Given this list of marker genes Rxylt1, Ddias, Gabrg3, Tm7sf3, Ptpn14, Dglucy (D-glutamate cyclase), Slc19a2, Hpcal1, Zbtb7b, Cpt1c, Ano3, Rap2a, Ggta1, Eda2r, Susd6, Trp53inp1, Sec14l5, Ddit4l, Tbc1d8, Bbc3, Zfp750, Inka2, Cep170b, Gne, Usp2, Tnfrsf10b, Cdkn1a, Ampd2, Nr1d1, Tmem19, Map3k20, Dcxr, Fas, Gm5046, Rhbdf2, H2aj (NCBI Gene Id 632401), Vps36, Trafd1, Pidd1, Hmcn2, Pierce1, Rap2b, Cgref1, Pmaip1, Baiap2, Tap1, Cdc42bpg, Zfp365, Ei24, Pdk4, Ephx1, Btg2, Gtse1, Aen, Phlda3, Kank3, Polk, Rnf169, Zmat3, Apaf1, Foxo3, Plk2, Prrg4, D630023F18Rik, Mab21l3, Ckap2, Slc66a3, Grhl3, Dennd2c, Lpin1, Bloc1s2, Usp32, Gpr75, Ercc5, Sesn2, Mapkapk3, Arap2, Stox2, Igdcc4, Ppm1d, Bax, Dcaf4, Ccng1, here is a description of the gene set: from publication Quintens R, Verreet T, Janssen A, Neefs M, Leysen L, Michaux A, Verslegers M, Samari N, Pani G, Verheyde J, Baatout S, Benotmane MA (PMID 25681390) The mammalian brain is especially sensitive to ionizing radiation during development, as shown by the increased occurrence of mental retardation and small head size in children who were in utero exposed to ionizing radiation after the atomic bombings of Hiroshima and Nagasaki. These effects of prenatal irradiation can be mimicked by irradiation of mouse embryos during the organogenesis period. In order to better understand the early effects of ionizing radiation on the embryonic brain and immature neurons, we performed a microarray analysis on brains from mice irradiated with different doses at E11 and E14, as well as primary cortical neuron cultures at 14 h in vitro. RNA was extracted at either 2 h (brains) or 6 h (neurons) post-irradiation. This gene set includes genes that were differentially expressed in at least two different conditions, to generate a bona fide list of early radiation-responsive genes in the embryonic mouse brain. Genes up-regulated in the mouse embryonic brain or immature neurons at 2 h or 6 h, respectively after exposure to 1 Gy dose of ionizing radiation. studied in species Mus musculus Mouse Gene Set: QUINTENS_EMBRYONIC_BRAIN_RESPONSE_TO_IR